Given this list of marker genes Dnase1l1, Fbh1, Dnase1, Cdkn2a, Foxl2 (forkhead box L2), Aifm1 (apoptosis-inducing factor, mitochondrion-associated 1), Il6, Cidea, Gata5, Endog, Dnase2a, Apex1, Apaf1, Trex2 (three prime repair exonuclease 2), Isg20, Blvra, Exog, Dnase2b, Hsf1, Atm, Igfbp3, Bax, Dicer1, Trex1, Setmar, Rexo4, Vps54, Mus81, Dffa, Dnase1l2, Nmnat1, Rgn, Dffb, Dnase1l3, here is a description of the gene set: species: Mus musculus Mouse Gene Set: GOBP_DNA_CATABOLIC_PROCESS The cellular DNA metabolic process resulting in the breakdown of DNA, deoxyribonucleic acid, one of the two main types of nucleic acid, consisting of a long unbranched macromolecule formed from one or two strands of linked deoxyribonucleotides, the 3'-phosphate group of each constituent deoxyribonucleotide being joined in 3',5'-phosphodiester linkage to the 5'-hydroxyl group of the deoxyribose moiety of the next one.